The following is a description of a gene set: Each fraction of mouse hematopoietic cells was purified by cell sorting from bone marrow of 8-week-old C57BL/6 mice, and its gene expression was analyzed. Genes up-regulated in comparison of B cells versus monocyte macrophages. from publication Konuma T, Nakamura S, Miyagi S, Negishi M, Chiba T, Oguro H, Yuan J, Mochizuki-Kashio M, Ichikawa H, Miyoshi H, Vidal M, Iwama A (PMID 21540074) studied in species Homo sapiens Human Gene Set: GSE27786_BCELL_VS_MONO_MAC_UP, and this is the list of marker genes: ACO2, ZNF383, PHLDA3, CYB561A3, GPATCH8, ZZEF1, TRMT2A (tRNA methyltransferase 2 homolog A), SLF1, KDM1B, LTV1, MAPK11, H2AC25, ATP5MF, WRNIP1, SF3B2, SOWAHA, MRPS18A, ATAD2B, ERGIC1, ZNF841, POLD1 (NCBI Gene Id 5424), PSMA3, COX17, AP1AR, PRR5, SMG1, TUFT1, ANKRD49, SOCS7, DMAC1, RWDD1, DDX24, CNIH1, PON2, RUVBL1, RPS16, IFT27, YOD1, ARIH2, OAT, SCYL1, OARD1, FAR1, SIGLEC10, SIT1, RAB10, UBA3, CIAO1, CYP51A1, TRIAP1, DOHH, CAMSAP2, ZMYND8, SCAF4, POLR2A, TET1, ZNF512B, NKRF, HNRNPA3, ANKS3, CAT, FASN, RETREG3, LPIN2, C17orf58, CRBN, ABL2, ERBB3, ARHGAP25, MTAP, RMND1, DNAJC9, TIMP4, HNRNPA1, PRPSAP1, ESCO1, FGF17, TECPR1, BCLAF1, BAHD1, NFRKB, BCL2L12, IFT140, FAM43A, SLC6A5, PHF23, CHCHD4, GMFB, UBR1, CREBRF, DNAAF5, KCNQ1OT1, PSMA6, CREB1, RPL22L1, MTNAP1, DAG1 (NCBI Gene Id 1605), RPL39, SMIM15, PHB2, ZNF124, CCT6A, TMEM135, PHF14, TSTD1, CSGALNACT1, MIGA1, ANAPC16, KBTBD11, DDX46, HSD17B12, CFAP20DC, PKD1, STRN3, NENF, KDM5A, BTG3, MRPL22, ENDOD1, AMMECR1L, NOP56, SF3A3, CABLES2, SHPK, RRP1, KHDRBS1 (NCBI Gene Id 10657), FXR1, FTO, TIMM13, PFAS, MARS1, OTUD5 (OTU deubiquitinase 5), SLC7A6, NAA35, UBE3A, USP34, RCC2, PTGR3, NDUFV1, TXNIP, TTC33, PLPP3, XPO6, DNAAF2, RPL17, SETD2, ELAC2, CXorf38, MNAT1, PRR3, DFFB, BMAL1, CHD8, ATP5F1D, GCSH, RNF2, SDHAF1, TSHZ1, DYNLL1, MSN, ITFG2, ATP5MC2, MARCHF5, CWC22, AFG2B, SETD4, JUND, IMMP1L (inner mitochondrial membrane peptidase subunit 1), SMTNL1, PSMD3, YIPF4, NMI, JAGN1, PDE4DIP, PHF20, IPO4, TMEM39B, POLR2G, NARS2, MIA3, POLR1H (RNA polymerase I subunit H), GSTT2, ENY2, CACTIN, TIMM9 (translocase of inner mitochondrial membrane 9), COPS7A, FAM174C, MYCBP2, CTCF, CCT7, ATRX, NDUFA12, CD99, UBTF, FAM120C, AGBL5, ARF6, EIF3G, POP1, WDR55